Given this list of marker genes SLC7A11, UNC13B, UPK3B (uroplakin 3B), CREB3L2, CD99, CENPI (NCBI Gene Id 2491), PPL, USP34, TOP6BL, ABLIM1, RBM8A, TBL1X, FH, HTRA1, GPC1, RASSF2, MRPS33, FAM171A1, NDRG3, MTCH1, CHST15, GNG12, CCNB2, AP1S2 (NCBI Gene Id 8905), COX7A2L (cytochrome c oxidase subunit 7A2 like), FBXL18, PPP1R7, CERK, SNF8, SEMA4F, KANK2, RAC1, GDE1, GNB1, PDXDC1, ME1, EBP, MYH10, GALNT10 (polypeptide N-acetylgalactosaminyltransferase 10), VTI1B, AKR7A2, RAP2B, MALL, CLIP4, CAP2, CDC42BPA, JAG2, EMC9, TPCN1, GYG2, EPB41L4B, FBXW2, FTH1P5, JAK1, NIT2, ALCAM, HAGH, ABCA12, CCND3, GAS2L1, DUSP14, PFDN1, FSHR, PDGFC, PDLIM2, SLC25A11, MYO5C, PALLD, TIMM10, NT5DC2, TYRO3, FAM114A1, SPA17, PAGR1, WSB2, MAPK1IP1L, GNPAT, MGAT4B, CAPN2, MAVS, GMPPB, ACO1, GPSM2, MCUR1, TMF1, ADD2, DARS2, IMPDH1, RITA1, OLFML2A, USP22, EML1, TRIM37, ITGAE, MED20, AOX1, SMTN, AQP3, SUV39H1, MXRA7, ARPC1A, GYS2, MAPK11, OXTR, MAP3K9, USP13, PDGFD, FBN2, PRKCA, TTC3, AMZ2, DDX41, HDHD5 (NCBI Gene Id 55649), ECHDC3, FZD2, CBX5, PRSS23, PDLIM3, FECH, ADCY3, ARHGAP28, ANKRD28, CTNNAL1, CNTN1, TNKS, ASAH1, MARF1, ARL3, HNRNPA0, PLCE1, AVEN (NCBI Gene Id 57099), DDB1, COTL1, PLXNA1, PREPL (NCBI Gene Id 9581), CTDSPL, ARPP19, COCH, PTDSS1, IVL, NR2F6, RAB40B, DLEU1, MAGEA8, ECHDC2, ERMAP (NCBI Gene Id 6306), CLK4, AHNAK, SCARA3, RAB13, GTF3A, HSD17B8, GRK6, CBX6, HGH1, INPP5A, IGSF3, CENPS, IPO9, SRI, MTMR2, AP1M2, RCN2, SPINT2, PIN1, EIF4G2, LIMS1, GSK3B, TMEM168, IMPDH2, TRIO, POU6F1, APPL2, TAX1BP3, LINC00667, AGBL5, GSTA4, HPCAL1, MPC2, DIP2C, KIAA0232, TUBA1A, PITPNA, TMX4, TRAK2, MOCS2, VOPP1, GALNT11, PADI3, EIF4B, UCP2, GET1, MRPL48, AHNAK2, RAD17, PXDN, PERP, MYBL2, NRCAM, FASTK, here is a description of the gene set: studied in species Homo sapiens Human Gene Set: GSE42021_CD24HI_VS_CD24INT_TREG_THYMUS_UP from publication Toker A, Engelbert D, Garg G, Polansky JK, Floess S, Miyao T, Baron U, Düber S, Geffers R, Giehr P, Schallenberg S, Kretschmer K, Olek S, Walter J, Weiss S, Hori S, Hamann A, Huehn J (PMID 23420886) Genes up-regulated in thymic T reg: CD24 high versus CD24 int. We investigated at which stage of maturation commitment to a stable Foxp3-expressing phenotype takes place. We assessed stability of Foxp3 expression in thymic Foxp3+ Treg subsets of different maturity, defined by CD24 expression. Next we compared gene expression profiles of Foxp3+ Treg subsets (+) of different maturity (24lo, 24int, 24hi) and could identify a set of genes that were specifically up or downregulated in Foxp3+ Tregs, but not in Foxp3- conventional T cells, in a maturation-dependent manner.